The following is a description of a gene set: Many symptoms associated with allergic asthma result from the sequelae of type 2 inflammation. Interleukin (IL)-25 promotes type 2 inflammatory responses, and T2M cells represent an IL-4 and IL-13 producing granulocytic IL-25 responsive population. We used microarrays to characterize the gene expression profile of T2M cells, and compared T2M cells to other inflammatory subsets (eosinophils, neutrophils, and macrophages) in the lungs of mice with IL-25-induced pulmonary inflammation. Human Gene Set: GSE36392_MAC_VS_NEUTROPHIL_IL25_TREATED_LUNG_DN Genes down-regulated in comparison of macrophages treated with IL25 versus neutrophils treated with IL25. from publication Petersen BC, Budelsky AL, Baptist AP, Schaller MA, Lukacs NW (PMID 22543263) studied in species Homo sapiens, and this is the list of marker genes: CDCA8, CDR2L, ZBTB8B, UBE2D3, RCVRN, AMPD2, GJB2, MUC5B, PKP1, CPLX3, LMNA, DSP, ZNF532, PSMD1, CNDP2, ILDR2, HK2, DMKN, BASP1, TNFSF11, TCP11, MAPK1, HOXC13, MET, EIF5A, LUZP1, TREM1, FRMD4B, TEKT4, SLC51A, LIPN, WNT8A, KIAA1549, MPST, BCHE, ADGRV1, CD53, TEX47, CDH23, RSPH14, PLA2G5, SOX14, NR3C2, AQP5, COPZ2, ERRFI1, IL1RN, ALPI, RNASEL, KIF1A, CCDC59, CASS4, ACP3, EYA2, MBD3L1, GALR2, CMC2, CABYR, FHOD3, NFKBIZ, SHISAL2B, CD6, DRC1, HMMR, CDR2, NLRP6, SFPQ, FLT1, PM20D1, INCENP, CFB, YTHDF3, CPEB4, DEPDC1B, HTR7, GPX7, HMOX1, TBC1D21, CDKN1A, RASEF, SLC7A11, PCDHAC1, EREG, IFRD1, PDGFA, NIBAN2, GPR65, PRNP, PACRG, DHRS3, HRH4, ATL1, RRS1 (NCBI Gene Id 90810), GPAT3 (glycerol-3-phosphate acyltransferase 3), MT1E, SPRED1, SLC6A3, SOCS3, FGD1, CYTH1, SEMA3D, SEMA6D, F7, GNPDA1 (glucosamine-6-phosphate deaminase 1), CREB3L4, IL1A, OLR1 (oxidized low density lipoprotein receptor 1), OTOG, GAS2L2, VAT1, NPAS1, SLFN12L, ZNF711, NGEF, VSTM2B, NFIA, SLC22A2, DHX32, IL1R1, MAPK6, EXOC3L4 (NCBI Gene Id 91828), CYP3A4, F2RL1, BBS7, GRHL3, MYO3A, PLPPR3, TFEC, MIP, TMEM88, NINJ1, CCR1, C1QC, NYX, SPO11, ZNF35 (NCBI Gene Id 7584), RADIL, EIF4G1, UXT, TMEM100, TOMM6, CCNB2, PLAGL1, COTL1, PYROXD2, STK40, PDX1, TNFRSF12A, PHLDA3, TNFRSF11B, PRKAR1A, CUL4B, TRIB1, NRP2, SRXN1 (NCBI Gene Id 140809), SH2D4B, PVALB, THPO, TMA16, BHLHA9, RBM44, RASL10B, PSMD12, MXI1, CCL22, B3GNT3, EXOC5, TIMD4, TMEM217, RASL11B, SOCS2, AQP4, STAB1, CSRP1, ANGPTL8 (NCBI Gene Id 55908), GPC1, ART5, RBBP8, B3GLCT, GTSE1, C1QB, SCAMP5, MVK, CGNL1, RMDN2, CLDN8, LYZL4, LAMB3, CMIP, WWTR1, HAPLN4, LMAN1, JAKMIP3, ACOT1, WNK1, PEPD, CD14, OSCAR, SYT7, CCN3